Given this list of marker genes GLI2, SIX3, PTCH1, RECQL, COLEC11, NFIX, SMOC1, NRAS, PEX19, HRAS, EFEMP2, TGIF1, here is a description of the gene set: species: Homo sapiens Human Gene Set: HP_ABNORMALITY_OF_THE_PREMAXILLA An abnormality of the premaxilla, the most anterior part of the maxilla that usually bears the central and lateral incisors and includes the anterior nasal spine and inferior aspect of the piriform rim. The premaxilla contains the bone and teeth of the primary palate. Abnormality of the premaxilla